Given this list of marker genes HDAC1, SIX4, SIX1, WNT10B, CTNNB1, HDAC2, here is a description of the gene set: species: Homo sapiens The progression of the fungiform papilla over time, from its formation to the mature structure. The fungiform papilla is a mushroom-shaped papilla of the tongue. Human Gene Set: GOBP_FUNGIFORM_PAPILLA_DEVELOPMENT